The following is a description of a gene set: electronically inferred by orthology from the curated human pathway part of: Calmodulin induced events This event has been computationally inferred from an event that has been demonstrated in another species.<p>The inference is based on the homology mapping from PANTHER. Briefly, reactions for which all involved PhysicalEntities (in input, output and catalyst) have a mapped orthologue/paralogue (for complexes at least 75% of components must have a mapping) are inferred to the other species. Reactome Pathway: CaMK IV-mediated phosphorylation of CREB species: Mus musculus, and this is the list of marker genes: Camkk1, Camkk2, Calm1